Given this list of marker genes Sf3b5, Ldhb, Nat8f3, Erdr1, Stmn1, Mdh2, Clk3, Sf3b2, Psmb8, Lsp1, Rplp0, Rbm26, Tomm6, Taldo1, Usp42, Zbtb47, Lrrc75b, Shisa5, Prdm16, Gsto1, Prxl2a, Pomp, Bloc1s1, Wdfy3, Arpc5, Mpc1, Phf5a, Mrps11, Eng, Etfb, Aurkaip1, Nabp2, Hspa1a, Ncbp2as2 (NCBI Gene Id 66051), Ngrn, Cfl1, Tmem160, Ppp1r15a, Tm4sf1, Hyal2 (hyaluronoglucosaminidase 2), Tnk2, Srpk2, Ndufb9, Nudt3, Nme7, Mpzl1, Elf2, Rasa2, Lgmn, Hnrnpa0, Cxcl14, Emid1, Cox5a, Gria2, Dbndd2, Mras, Baiap2, Napa, Tmed3, Tle5, Arpc4, Rpl13a, Aldoc, Mgst1, Camk2n1, Per3, Psmc2, Mertk, Rbm39, Park7, Zfp444, Pou3f3, Selenok (NCBI Gene Id 80795), Hacd2, Sdhc, Gstm1, Zc3h13, Lyz2, Nupr1, C3, Fxyd1, Cxcl1, Washc3, Srrm1, Gnb1 (NCBI Gene Id 99986), Pcbp2 (NCBI Gene Id 18521), Sh3bgrl3, Paqr6, Ano6, Anp32b, Irf2bpl, Kif21a, Dhx36, Snrpc, Cuedc2, Slc9a6, Crbn, Emc4, Fndc3a, Mettl9, Ssr1, Tut4, Myc, Rpl18a, Pcsk1n, Mir9-3hg, Cldn11, S100a10, Xpo6, Nnat, Megf9, Commd2, Endog, Gon4l, Crip2, Pfdn1, Rab4b, Tmem43, Trp53inp1, Prkci, Tmed9, Gstp1, Vps35, Taf13, Psmb4, Pard3, Trf, Tceal9, Hmgb1, Limd2, Fam50a, Kdm6b, Hmgn2, Nicol1, H2-D1, Phf20l1, Swi5, Wbp2, Slc15a2, Dync1h1, Gstm5, Rrp1 (ribosomal RNA processing 1), Rhoj, Lgals9, Calm3, Ifi27, Sfxn5, Pygl, Ctsl, Pabpn1, Tmsb4x, Rpl13, Rps9 (ribosomal protein S9), Ptpn1, Vim (vimentin), Vcf1, Sun1, Nrxn2, Tubb4a, Aamp, Ift27, Tspan4, Mfn2, Vamp8, Rhoc, Mif, Mdh1, Inppl1, Calm2, Ppp5c, Rest, Nkain4 (NCBI Gene Id 93797), Mfap1b, Bckdha, Dtx3, Acyp2, Psmb9, Hmgn3, Psd2, Ly6d, Nsmce1, Tulp3 (TUB like protein 3), Atp6v1g1, Bod1, Hes5, Dynll1, Arl16, Haghl, Akr1a1, Lmna, Ubb-ps, Snx6, Yipf3, Inhbb, Fgfr1op2, Igfbp7, Ubald1, Trp53i13, Gfer, Spen, Tigd2, Vps28, Kti12, Jund, Spr, Syngr2, Brd10, Mtss2, Ehmt1, Oga, Arid5a, Pde6d, Isca2, Mrps12, Iqsec1, Brd2, Sparc, Lrrc47, Prdx5 (peroxiredoxin 5), Mtrf1l, Kcnk2, Ubiad1, Syf2, Fnbp1, Cuta, Sri, Psmb6, Dynlrb1, Sec11a, Ccnd1, Csrp2, Srp14, Gpx4, Cend1, Ncoa1, Phlpp1, Zmym6, Fbxo2, Drap1, Mylip, Arhgef40, Ripk2, Shisa4, Pdcl3, Sod3, Lamtor4, Otub1, Selenow, Gpr173, Ubxn1, Yipf6, Rpl6, Ap2a1, Kansl3, Dmac1, Tmtc2, Lhpp, S100a16, Rfx5, Hpcal1, Mrps16, Commd4, Rsrc2, Adgrl1, B2m, Ssb, Stat1, Gm11627, Npm1 (nucleophosmin 1), H3f3b, Rpl4, Yy1, Chchd10, Fos, Naa20, Lgals3, Npc2, Ftl1, Lxn, Gadd45gip1, Tubb6, Ddt, Vegfa, Ik, Trappc6b, Cirbp, Thy1, Oaz1, Cd63, Atp6v0b, Capg, Syp, Csf1r, Ifitm3, Pmm2, Frg1, Ipo13, 1110065P20Rik, Tagln2, Fuom, Has1, Vti1b, Snrpb, Rtl8c, Gtpbp1, Filip1l, Szrd1 (SUZ RNA binding domain containing 1), Rps6ka1, Bdh1, Specc1l, Tmem14c, Uqcc2, Snrpd3, Snrnp27, Plpp3, Tspan13, Synrg, Sox9, Ramac, Abl1, Camk1, Ywhah, Arl3, Boc, Rheb, Tenm3, Arglu1, Psmc3, Nfic, Cystm1, Hprt1, Ubxn8, Bub3, Sap18, Pqbp1, Tspo, Psip1, Hadha, Lrp1, Phf21a (NCBI Gene Id 399586), Anapc11, Uqcc3, 2700097O09Rik, Vegfb, Matk (megakaryocyte-associated tyrosine kinase), Lrif1, Mrpl2, Eif5a, Lmo4, Gcat, Rhog, Clk1, Eif6, Hnrnpul1, Gtf2b, Gsn, Pitpnm2, Kansl1, Cope, Sel1l, Btbd10, Hebp1, Tra2a, Naa10, Rab34, Mtfr1l, Psmd12, Dnlz, Gpx3, Sfr1, Myoc (NCBI Gene Id 98481), Eif3k, Fam181b, Ssna1, Atp5if1, Arl8a, Idh2, Pfdn6, Add1, Naa80, Arl2, Mettl26, Hint1, Gt(ROSA)26Sor, Dnajc9, Myadm, Ifngr1, Olfm2, Lsm10, Klf5, Ndufa12, Pigc, Sypl2, Lrrc4b, Mgp, Sat1 (spermidine/spermine N1-acetyl transferase 1), Pcolce, Pfdn5, Syn1 (synapsin I), Ptms, Abhd11, Pnrc1, Rps3, Selenom, Fkbp3, Smim20, Pabpc1, Mpv17l2, Sox2, Cfp, Sarnp, Ube2q1, H2-K1, Trim13, Hdac7, Hcfc1r1, Tmeff2, Cct5, Dtx1, Tmem119, Wdr6, Nedd8, Foxn2, Phpt1, Eno1b, Fosl2, Tcirg1, Malat1, H2aj, Prrc2c, Arhgdia, Arhgdib, Capns1, Ubb, Suclg1, Psme3ip1, Dnajc30, Ube2l3, Cdc5l, Tsc22d4 (NCBI Gene Id 78829), Ip6k2, Ybx1, Mageh1, Sod2 (NCBI Gene Id 20656), Tgfbi, Adrm1, Fkbp2, Grcc10, Cotl1, Dcn, Rps24, Eif3f, Rdh10, Mapk1ip1l (mitogen-activated protein kinase 1 interacting protein 1-like), Pfn1, Pld2, Pura, Rarres2, here is a description of the gene set: from publication Tabula Muris Consortium (PMID 32669714) species: Mus musculus Mouse Gene Set: TABULA_MURIS_SENIS_BRAIN_NON_MYELOID_ASTROCYTE_AGEING